Given this list of marker genes Cxcr3, Ackr2, Ccr9, Ccr1l1, Ccr5, Ccr3, Ackr3, Cxcr1, Ccr4, Plp2, Zfp36, Pdpn, Cxcr5, Cx3cr1, Prp2rt, Fgf2, Ackr4, Itga4, Itgav, Ccr8, Itgb1, Ackr1, Ccr7 (NCBI Gene Id 12775), Cxcr4, Xcr1, Cxcr6, Itgb3, Ccr10, Ccr1, A2m, Ccr2, Ccr6, Hmgb1, Cxcr2, Ccrl2, here is a description of the gene set: studied in species Mus musculus Mouse Gene Set: GOMF_CHEMOKINE_BINDING Binding to a chemokine. Chemokines are a family of small chemotactic cytokines; their name is derived from their ability to induce directed chemotaxis in nearby responsive cells. All chemokines possess a number of conserved cysteine residues involved in intramolecular disulfide bond formation. Some chemokines are considered pro-inflammatory and can be induced during an immune response to recruit cells of the immune system to a site of infection, while others are considered homeostatic and are involved in controlling the migration of cells during normal processes of tissue maintenance or development. Chemokines are found in all vertebrates, some viruses and some bacteria.